The following is a description of a gene set: The human mixed lineage leukemia (MLL) gene is involved in about 50 different chromosomal translocations, associated with the disease phenotype of acute leukemia. However, the normal function of MLL is less understood. Homozygous knockouts of murine Mll were embryonal lethal, while heterozygous disruption led to aberrant hox gene expression associated with skeletal malformations, growth retardation, and impaired hematopoiesis. To understand MLL functions on the molecular level, gene expression profiling experiments were performed with a pair of murine cell lines (MLL(+/+) and MLL(-/-)). Microarray hybridization experiments revealed 197 potential target genes that are differentially expressed, providing new and important clues about MLL functions. Mouse Gene Set: SCHRAETS_MLL_TARGETS_UP Genes up-regulated in fibroblasts from MLL knockout mice. studied in species Mus musculus from publication Schraets D, Lehmann T, Dingermann T, Marschalek R (PMID 12789274), and this is the list of marker genes: Gpc4, Acta2, Nes, Cavin2, Serpine2, Ifi202b, Fzd6, Mmp11, Fas (NCBI Gene Id 14102), Ifi204, Tob1, Dcn, Tom1l1, Ndn, Cadm1, Mlf1, Ctsc, Msx2, Btg3, Tpd52l1, Tspan7, Hoxd8, Cd34, Gm2a, Ctsz, Mmp10, Peg3, Sumo3, Tnc, Hoxa1, Fos, Tnnt2, Fhl1, Foxg1